The following is a description of a gene set: Mouse Gene Set: GOBP_NEGATIVE_REGULATION_OF_TRANSMISSION_OF_NERVE_IMPULSE studied in species Mus musculus Any process that stops, prevents, or reduces the frequency, rate or extent of transmission of a nerve impulse, the sequential electrochemical polarization and depolarization that travels across the membrane of a neuron in response to stimulation., and this is the list of marker genes: Chrnb2, Avp, Cntnap2 (NCBI Gene Id 66797), Avpr1a, Glra1, Hcrt, Mtnr1b, Gpr35, Kcnc4